The following is a description of a gene set: from publication Yevshin I, Sharipov R, Kolmykov S, Kondrakhin Y, Kolpakov F (PMID 30445619) studied in species Mus musculus Genes containing one or more binding sites for (Mta3) in their promoter regions (TSS -1000,+100 bp) as identified by GTRD version 20.06 ChIP-seq harmonization. Mouse Gene Set: MTA3_TARGET_GENES, and this is the list of marker genes: Acvr1c, Tmem215, Dnmt3a, Zfp148, Npepl1, Rassf2, Shld2, Atp6v1h, Adamts19, Ckmt1, Plcb1, Gpat3, Wwc2, Dab2ip, Rfx4, Rps29, Abcc5, Rnf138, Ttll13, A330008L17Rik, 1700028I16Rik, Mob3c, Plcxd1, Cxxc5, Uhrf1, Tnfrsf11a, Cnot11, Fam83h, Znrf1, Gm28523, Gm5106, Brk1 (BRICK1, SCAR/WAVE actin-nucleating complex subunit), Hat1, B4galnt1, Bmper, Utp14b, Gm15743, Cdh8, 4930519P11Rik, Mras, A930012L18Rik, Tmem131l, Vmn1r4, P2rx4, Bbs12, Cetn3, Fam234b, Ccdc102a, Pnma1, Bnc2, Foxp1, Kif26a, Sphk1, Tmem229b, Mgat4b, Tmie, Egr2, Gm14320, Ank1, Arf6, Keap1, Sigirr, Lrrc38, Tmppe, Mex3a, Plekhg1, Camta1, Slc38a1, Gm16675, Slc39a13 (solute carrier family 39 (metal ion transporter), member 13), Zbtb4, Mxi1 (NCBI Gene Id 17859, MAX interactor 1, dimerization protein), Mir148a, Nipal2, Tirap, Col27a1, Wipf1, Gm15612, Saysd1, 1810034E14Rik, Cc2d1a, Tmem120b, Rpl36al, Fdx1, Glud1, Gm20036, Smim14, Ube2f, Ciz1, Srpra, Ak4, Tjp2, Stc2, Gm13580, Gm53, Fbxw4, Gm4473, Psat1, Ghdc, Als2cl, Frg2f1, Bbc3, Grin2a, Slc16a5 (NCBI Gene Id 217316), E330017L17Rik, Cbll1, Meiosin, Cmtm7, Tmeff1, Tmem116, Got1, Gabarapl2, Rnf145, Msx3 (NCBI Gene Id 212466), Snx33, Efcc1, Gtf2ird1, Rasal3, Zfp296 (NCBI Gene Id 80575), Oprd1, Irak3, Prkag2, Tmbim4, Hcn4, Dagla, Gm11772, Rasgrp2, 2500002B13Rik, Xrcc3, Glb1, Gm7291, Tmem171, Fam241b, Qki, Telo2, Gm15688, Ffar2, Wnt5b, Ltbp1, Zeb1, Nudt3, Canx, Prkcb, Tal1, Slc20a1, Cic, Mir7b, Phlda3, H60b, Nr5a2, 3110053B16Rik, Bdh1, Gm5540, Scrt1, Dnaja4, Arid3c, Gm15706, Unc5c, Mpc2, Itpk1, Rev3l, Gm14343, Camk2n1, Rmnd5a, Dnajb5, Satb2, Sstr2, 4930589O11Rik, 1190005I06Rik, Apoh, Nab2, Add3, Rtkn (rhotekin), Fam117b, Cox15, Myo19, Gm11767, Atg16l2, Gpr75, Abcg1, Rragd (Ras-related GTP binding D), Cby1, Cntn5, Gm38293, Alyref2, Gm26562, Cdc14b, Pdgfb, G3bp1, Cdk8, Zswim8, Disp3, Gm11695, Phc1, Eno1, Gm17244, Tspan9, Cacng2, Etv4, Rab12, Dis3l, Elf1, Birc6, Gm16096, Lzts2, Efcab2, Atp6v1c2, Kctd15, Gm12536, Gnal, Slc25a13, Mpv17l, Hk1os, Synj1, Klc2, Gm13162, Carmil3, Klhl10, Igf2bp3 (NCBI Gene Id 72471), Tle4, B130011K05Rik, Fbxo17, Pabpc1, Arhgap27os1, Gnl1, Ss18, Gm10501 (NCBI Gene Id 100303733), Raet1e, Mfsd4b5, Hrh3, Ramp2, Enah, Shq1, Cbln1, Zeb1os1, Fam227a, BC034090, Crnde, Herpud1, AI661453, Teddm2, Rsad1, Adamtsl3, Prdm2, Ndrg1, Rbsn (NCBI Gene Id 78287), Adcyap1r1, Yap1, Eef1d, Tbx20, Gng10, Col4a2, Pde8b, Kcnh4, Acot4, Rab3a, Zfp568, Prodh, Nos1, Irf2, Prickle1, Cobll1, Sox11, Gm13620, Cdca8, Gm16576 (predicted gene 16576), Glul, Rnf19b, Zbtb7a, Gprin1, Trim36, Sun2, Tmem117, Fkbp5, Spice1, Sap25, Gm16318, Tpd52, Cenpx, Gfra4, Stox1, Wdr93, Mindy2, 1700007L15Rik, Calu, Ajap1, Tuba1c, Msl2, Smim33, Iqank1, Adprs, Zmiz1, Foxk2, Anp32e, Cetn4, Kcnk15, 4930432B10Rik (NCBI Gene Id 74619), Fam53b, E230016M11Rik, Rbm38, Slc6a17, Xxylt1, Lsm2, Gadd45g, 1700086P04Rik, Ube2q2, Hk1, Srgn, Gm15510, Tdg, A730020E08Rik, 9330151L19Rik, Wfikkn1, Celrr, Pex11a (peroxisomal biogenesis factor 11 alpha), Sncaip, Nf2, Phospho1, Rgl1, Tmsb10, Plvap, Cnnm1, Ints13, Taok3, Morc1, Tmc6, Zfyve16, Nrros, Tmbim1, Plcb4, Tpd52l1, Rasl11a, Trmt9b, Rgma, Zfp783, Agpat2, Rai14 (retinoic acid induced 14), Slc16a6, Rom1, Fgfr1, Airim, Piezo1, Pcolce, Vamp2, Kdm7a, Foxj3, Auts2 (autism susceptibility candidate 2), Bmpr2, Ecsit, Pakap, Lrrfip1, Bbx, Kank2, Nxph2, Itga5, Cluh, Abtb1, Gldn, Mal, 2900005J15Rik, Dram1, A930004D18Rik, Mroh6 (maestro heat-like repeat family member 6), Rarg, Pcbp4, Ccdc106, Ube2e1, Bahcc1, Tex261, Cdkn2a, Baiap2 (brain-specific angiogenesis inhibitor 1-associated protein 2), Ssc4d, Gm11423, Ldb1, Igfbp2, Nkx1-1, Rapgef6, Kctd11, Hnf1b, Trib1, Pik3cd, Tnrc18, Prr3 (proline-rich polypeptide 3), Peds1, Steap2, Gm29228, Dazap1, Igdcc3, Rhob, Slc16a9, Apba1, Cdk6, Brme1, 1810010K12Rik, Fbxo30, Lrch1, Yars1, Bmpr1b, Tenm4, Mef2c, Nt5c3b, Gtf2i, Shb, Zcchc2, Mreg, Mllt1, Adam17 (NCBI Gene Id 236174), Eml3, Stmp1, Zfp715, Tspan2, Mtmr10, Esco1, Rxylt1, Rln1, Nemp1